The following is a description of a gene set: Human Gene Set: MIR6741_3P Genes predicted to be targets of miRBase v22 microRNA hsa-miR-6741-3p in miRDB v6.0 with MirTarget v4 prediction scores > 80 (high confidence targets). from publication Chen Y, Wang X (PMID 31504780) studied in species Homo sapiens, and this is the list of marker genes: UBQLN1, MKX, KCNB1, MAB21L1, FOXF1